The following is a description of a gene set: Human Gene Set: GOMF_HISTONE_H3K4ME3_READER_ACTIVITY species: Homo sapiens A histone reader that recognizes a histone H3 trimethylated at lysine 4., and this is the list of marker genes: PHF1, PYGO1, ING3 (NCBI Gene Id 54556), MORC3, ING4, PHF8, MORC4, ING1, TAF3, CHD1, CHD8, SPIN4, ING5, PHF19, PHF2, RAG2, SPIN3, SPIN2A, ZCWPW1, SPIN2B, CXXC1, SPIN1, KMT2E, ZCWPW2, ING2, SGF29